Given this list of marker genes ATRIP, CDC6, CNOT3, BBS5, NKX2-5, MEF2C, NUP85 (nucleoporin 85), ALG12, CHSY1, DONSON, RAF1, GLI3, PRKACB, DYNLT2B (dynein light chain Tctex-type 2B), PYROXD1, IGF2, PIK3C2A, CSPP1, PTH1R, IFT27, AKT1, PUF60, SMARCC2, PKDCC, NAA10, IFT43, CDC45, SIK3, BCOR, BMPR1B, MKS1, SCLT1, HSPG2, B9D2, LBR, L1CAM, IQCE, FGFR3, NCF1, BUD23, KIFBP, SIAH1, CEP55, NFIX, DDX59, BUB1, PIGY, NEDD4L, TBX1, BUB1B, BBS2, CCNK, RRAS2, RAB34, HOXD13, WDPCP, HNRNPR, AMER1, GTF2IRD1, KDM6A, SCAPER, FANCM, ATP2B1, RB1, JUP, INPP5E, LIG4, AKT3, DYNC2H1, NPR2, GTF2I, FRA10AC1, SMARCD1, LZTFL1, UBE3B, SHANK3, CSNK2A1, POLA1, BBS12, BRCA2, LTBP1, LZTR1, ATRX, MYCN, UBR1, MITF, BRF1, CHD8, BBS9, TBX5, TFAP2B, RAB18, RASA2, H4C3, CAPRIN1, OGT, IFT122, TMEM107, ERCC4, RFC2, SPRED1, MLXIPL, GATA4, MIA3, TRPS1, SPEN, PACS2, SOX6, SLC9A7, SMOC1, KAT8, UBA2, GTF2IRD2, GATA5, PUM1, CITED2, HMGA2, COX4I1, CDKN1C, ARMC9, CCDC22, NSD2, SMC1A, DSP, RUNX2, KDM5B, COL11A1, KMT2B, CDT1, LMBR1, RBM8A, TMEM67, H3-3B, SMAD4, CBL, EVC, TRPV4, GJA5 (NCBI Gene Id 2702), LMNB2, SF3B4, RNF216, IFT140, C2CD3, KMT2A, FANCB, GNPNAT1, KRAS, RSPRY1 (NCBI Gene Id 89970), TBX3 (T-box transcription factor 3), MAPK1, HNRNPK, TRPM3, TCTN2, QRICH1, ARID1B, KDM1A, CKAP2L, TBX4, KIAA0825, ARID2, MAPRE2, MKKS, STAG1, PNPLA6, FLT4, MRAS, BRAF, GRB10, MACROH2A1, SMO, LUZP1, NOG, NSUN2, RBBP8, AHDC1, BCR, AMMECR1 (AMMECR nuclear protein 1), FANCI, PAFAH1B1, SMC3, HDAC8, EFNB1, TMEM231, PITX1, MAN1B1, SPECC1L, PAICS, ODC1 (ornithine decarboxylase 1), GATA6, SEMA3E, ORC6, EP300, PIEZO2, OFD1, USP7 (ubiquitin specific peptidase 7), BBS4, PIGN, HDAC4, IQSEC2, SETBP1, CCDC8, SATB2, AP1G1, RAI1, HNRNPH1, TGDS, KIF15, BRIP1, IFT52, MECOM, DYM, GPC4, SLX4, DACT1, BMP4, NKX2-6, LIFR, CC2D2A, TFAP2A, SUFU, GNAS, FANCF, GJA1, POLR1A, DHPS, XRCC2, MMP23B, CENPE, PDE6D, ADAMTS15, LIMK1, TELO2 (NCBI Gene Id 9894), CCDC47, ORC4, HOXA11, CEP57, SKI, RAD51C, RPL10, NEK1, GDF5, FLNA, RAB23, PIGH, KCNAB2, DHCR7, EIF4H, BMP2, WDR19, RRAS, CEP19, KIF7, ZNF292, SIN3A, CD96, TWIST2, EHMT1, TRAPPC9, ATP6V1B2, BBIP1, RPGRIP1, ELN, ZC4H2, SPRED2, STAG2, CHRNA7, MBD5, BRD4, WIPI2, DPAGT1 (dolichyl-phosphate N-acetylglucosaminephosphotransferase 1), NAA20, TWIST1, ARID1A, CIBAR1 (CBY1 interacting BAR domain containing 1), TBC1D24, MEIS2, EIF4A3, KDR, NEXMIF (NCBI Gene Id 340533), TMEM216, DEAF1, SH3PXD2B, COL2A1, NIN, RIT1, CHD6, ARPC4, IRX5, STX1A, NONO, BRAT1, CSGALNACT1, PRDM16 (PR/SET domain 16), RERE, RAC1, SOS1, SMARCB1, HYLS1, SALL1, MAD2L2, MAP1B, LEMD3, GPC3, RAD51, WDR4, ACVR1, FZD2, IGF1, TCF20, DYNC2I2 (dynein 2 intermediate chain 2), KDM6B, WNT7A, MBTPS2, GLI2, LMX1B, FGFR2, ANKRD11, SCNM1, TRIO, MAF, CFAP418, ERF, AGO2, METTL27, EVC2 (NCBI Gene Id 132884), ZNF462, PIGS, FANCD2, RFWD3, SMARCA2, EXT2, GDF1, PCNT, CCND2, KAT6B, DYNC2LI1, FKBP6 (NCBI Gene Id 8468), TTC8, CPLANE1, WDR35 (WD repeat domain 35), ROR2, PIK3R2, KDM5A, PHF21A, FGF16, CEP290, DNAJC30, ADNP, RAD21, BAZ1B, WDR11, FANCE, PLAG1, UBE2T, RAB11B, PPP2R1A, SMARCE1, PTPN11, EMG1, OTUD5, EBF3, CASZ1, IFT172 (intraflagellar transport 172), CEP120, DVL3, IHH, SHOX, CDH11, AFF2, TMEM237, CLIP2, PQBP1, GMNN, TRIM32, FLNB, ZMYM2, GABBR1, TRRAP, TP63, RPGRIP1L, H19, VPS13B, TRAIP (NCBI Gene Id 10293), CUL4B, MEGF8, BLM, ARL6, NRAS, KCTD1 (potassium channel tetramerization domain containing 1), CTCF, KIAA0753 (NCBI Gene Id 9851), SLC26A2, CANT1, YWHAE, XYLT1, BPTF (NCBI Gene Id 348241), REV3L, TMEM218, MASP1, PACS1, OBSL1, AUTS2, FANCC, FLII, UBE3A, MAX, FGD1, HIC1, SC5D, ATG7, GABRD, ATR, PDPN, TCTN3, MECP2, BBS10, SOS2, SPOP, CREBBP (NCBI Gene Id 1387), JAG1, SOX11, CCDC28B, TMEM147, TBX15 (T-box transcription factor 15), CHD7, VPS37D, SNRPB, IFT80, PLXND1, PALB2, ZFPM2, MAPK8IP3 (mitogen-activated protein kinase 8 interacting protein 3), PHIP (NCBI Gene Id 83843), CNOT2, FBXW11, FANCG, FANCL, FANCA, CUL7, TAF4, SDCCAG8, CRKL, BBS7, RNU4ATAC, NPHP1, UBE4B, DYNC2I1, WNT5A, TMEM270, XRCC4, BUB3, MYL11, NUP37, ALDH1A2, DDX11, TPR, KCNK4, BRCA1, TAF6, WDR26, SRCAP, TCTN1, HOXA13, SOX4 (SRY-box transcription factor 4), PRKCZ, B9D1, CHST3, CCNQ, TTC21B, PORCN, NIPBL (NCBI Gene Id 25836), CCDC32, TRIP13 (NCBI Gene Id 9319), ABL1, ZNF141, SLC2A10 (solute carrier family 2 member 10), KCNJ2, CEP152, JARID2, KLF13, SNRPN, TGFBR1, ESCO2, PRR12, SMARCA4, CLCN3, ZDHHC9, GNB2, COL27A1, PIGL, ERI1, DPF2, KPTN, TBL2, IFT74, PLK4, KMT2D, B3GLCT, KDM4B, DVL1, DNA2, TXNDC15, SLC29A3, TMCO1, GJA8, BHLHA9, ALX3 (ALX homeobox 3), BBS1, ORC1, NXN, PLAA, here is a description of the gene set: species: Homo sapiens An abnormality affecting one or both 5th fingers. Abnormal 5th finger morphology Human Gene Set: HP_ABNORMAL_5TH_FINGER_MORPHOLOGY